Given this list of marker genes SEC23B, SRGAP1, ARID2, HRAS, APC, PDE11A, DPF2, DICER1, JAG1, SMARCE1, MINPP1, SOX4 (SRY-box transcription factor 4), FOXE1, SMARCA4, NRAS, HABP2, SMARCC2, NKX2-1, PRKAR1A, SOX11, SMARCB1, ARID1B, ARID1A, SMARCD1, here is a description of the gene set: Papillary thyroid carcinoma Human Gene Set: HP_PAPILLARY_THYROID_CARCINOMA The presence of a papillary adenocarcinoma of the thyroid gland. studied in species Homo sapiens